Given this list of marker genes MSH2, XRCC6, POLD2, ACO2, CHAF1A, FNTA, C1D, DFFA, UBE2V2, PRIM1, SNRPC, UGP2, CSNK2B, EZH2, PSMD14, RANBP1, FKBP1A, EIF2B1, MTIF2, TYMS, MAZ, SNRPD3, PRKDC, CCT4, SUMO1, CKS1B, CDC6, EIF2S1, EWSR1, TMEM131, here is a description of the gene set: studied in species Homo sapiens Bone marrow plasma cells (PCs) from 74 patients with newly diagnosed multiple myeloma (MM), 5 with monoclonal gammopathy of undetermined significance (MGUS), and 31 healthy volunteers (normal PCs) were purified by CD138(+) selection. Gene expression of purified PCs and 7 MM cell lines were profiled using high-density oligonucleotide microarrays interrogating about genes. On hierarchical clustering analysis, normal and MM PCs were differentiated and 4 distinct subgroups of MM (MM1, MM2, MM3, and MM4) were identified. The expression pattern of MM1 was similar to normal PCs and MGUS, whereas MM4 was similar to MM cell lines. Clinical parameters linked to poor prognosis, abnormal karyotype (P =.002) and high serum beta(2)-microglobulin levels (P =.0005), were most prevalent in MM4. Also, genes involved in DNA metabolism and cell cycle control were overexpressed in a comparison of MM1 and MM4. In addition, using chi(2) and Wilcoxon rank sum tests, 120 novel candidate disease genes were identified that discriminate normal and malignant PCs (P <.0001); many are involved in adhesion, apoptosis, cell cycle, drug resistance, growth arrest, oncogenesis, signaling, and transcription. A total of genes, including FGFR3 and CCND1, exhibited highly elevated (spiked) expression in at least 4 of the 74 MM cases (range, 4-25 spikes). Elevated expression of these genes was caused by the translocation t(4;14)(p16;q32) or t(11;14)(q13;q32). Thus, novel candidate MM disease genes have been identified using gene expression profiling and this profiling has led to the development of a gene-based classification system for MM. Top genes up-regulated in MM4 vs MM1 subgroup of multiple myeloma samples. Human Gene Set: ZHAN_MULTIPLE_MYELOMA_SUBGROUPS from publication Zhan F, Hardin J, Kordsmeier B, Bumm K, Zheng M, Tian E, Sanderson R, Yang Y, Wilson C, Zangari M, Anaissie E, Morris C, Muwalla F, van Rhee F, Fassas A, Crowley J, Tricot G, Barlogie B, Shaughnessy J Jr (PMID 11861292)